Given this list of marker genes IL2RB, COL11A1, TRAPPC2, PRG4, COL2A1, COL9A2, CD247, STAT4, SMAD2, MMP13, ANKRD55, IL2RA, PTPN22, SMAD3, PTPN2, here is a description of the gene set: Human Gene Set: HP_KNEE_OSTEOARTHRITIS species: Homo sapiens Knee osteoarthritis